The following is a description of a gene set: In plasmacytoid dendritic cell induction of type I IFNs critically depends on IFN regulatory factor 7 in TLR7 and 9 signaling. IRF-7, but not IRF3, interacts with MyD88, TRAF6, and IRAKs and translocates to the nucleus upon phosphorylation.<p> TLR7/8 signaling was shown to induce IRF5 activation along with IRF7, while IRF8 and IRF1 were reported to be implicated in TLR9 signaling. Reactome Pathway: TRAF6 mediated IRF7 activation in TLR7/8 or 9 signaling studied in species Homo sapiens part of: MyD88 dependent cascade initiated on endosome, and this is the list of marker genes: UBB, TRAF6, TLR9 (NCBI Gene Id 54106), UBE2V1, IRF7, UBE2N, RPS27A, TLR7, IRAK1, MYD88, IRAK4, UBC, UBA52